Given this list of marker genes Cul1, S100b, Ly96, Mapk14, Map2k7 (mitogen-activated protein kinase kinase 7), Map2k3, Tab3, Irak1, Map2k4, Jun, Ager, Mapk9, Nlrc5, Peli2, Dusp7 (dual specificity phosphatase 7), Ppp2r5d, Nfkbia, Hmgb1, Ticam2, Mapk7, Mapk3, Vrk3, Tifa, Nfkb1, Ppp2r1b, Rps27a, Mapk8, Rela, Nkiras1, Tlr4, Map2k6, Dusp6, Ecsit, Cd14 (CD14 antigen), Rps6ka5, Tab2, Ube2n, Casp8, Ikbkb, Nfkb2, Nlrx1, Ube2v1, Fos, Tab1, Lrrc14, Map3k8, Mapk11, Nfkbib, Ubb, here is a description of the gene set: Reactome Pathway: TRAF6 mediated induction of NFkB and MAP kinases upon TLR7/8 or 9 activation part of: MyD88 dependent cascade initiated on endosome electronically inferred by orthology from the curated human pathway This event has been computationally inferred from an event that has been demonstrated in another species.<p>The inference is based on the homology mapping from PANTHER. Briefly, reactions for which all involved PhysicalEntities (in input, output and catalyst) have a mapped orthologue/paralogue (for complexes at least 75% of components must have a mapping) are inferred to the other species. studied in species Mus musculus